Given this list of marker genes Ift122, Ift70a1, Ift70b, Ift172, Ift20, Ift88, Ift27, Ift74 (NCBI Gene Id 67694), Ift25, Ccdc38, Ift56, Ift80, Ift46, Cluap1, Ift57, Cilk1, Ift52, Traf3ip1, Ift22, Ift81, here is a description of the gene set: Mouse Gene Set: GOBP_INTRACILIARY_ANTEROGRADE_TRANSPORT studied in species Mus musculus The directed movement of large protein complexes along microtubules from the cell body toward the tip of a cilium (also called flagellum), mediated by motor proteins.